Given this list of marker genes COX15, COX16, MT-CO1, COX5A, COX10, COX17, SURF1, COX8A, TACO1, COX6B1, COX20, COX19, COA6, PET100, COX6A1, PNKD, NDUFA4, MT-CO3, TMEM177, HIGD1A, COX7C, COA3, COX18, CMC1, COX7A2 (NCBI Gene Id 1347), COX4I1, SMIM20, COX14, COX5B, MT-CO2, COX6C, COX7B, PET117, COX11 (NCBI Gene Id 1354), here is a description of the gene set: Mitochondrial complex IV assembly Human Gene Set: WP_MITOCHONDRIAL_COMPLEX_IV_ASSEMBLY species: Homo sapiens